Given this list of marker genes Exosc7, Gtpbp1 (GTP binding protein 1), Mtrex, Pan2, Exosc2, Zfc3h1, Carhsp1, Wdr74, Exosc5, Zfp36, C1d, Mphosph6, Exosc10, Pan3, Las1l, Exosc4, Exosc6, Exosc3, Dis3l, Pnpt1, Exosc8, Nvl, Dis3, Exosc1, Exosc9, Supv3l1, here is a description of the gene set: Mouse Gene Set: GOCC_EXORIBONUCLEASE_COMPLEX studied in species Mus musculus A protein complex which is capable of exoribonuclease activity.